The following is a description of a gene set: Binding to a phospholipid, a class of lipids containing phosphoric acid as a mono- or diester. Mouse Gene Set: GOMF_PHOSPHOLIPID_BINDING species: Mus musculus, and this is the list of marker genes: F10, Carmil2, Defb7, Defb5, Amer3, Nr5a1, Atp8b1, Rasgrp1, Cd300lf, Trim72, Myo1e, Map1lc3a, Cidea, Plek2, Cpne8, Arap2, Syt5, Rapgef6, Hgs, Vil1, Syt11, Slc9a3, Snx31, Jchain, Gramd2a, Pla2g2c, Ighm (immunoglobulin heavy constant mu), Gramd1b, Psd2, Atp13a2, Apoh, Irgm1, Pxk, Sytl5, Pla2g4a, Arap3, Epb41, Syt12, Pla2g2d, Rs1, Myof, Snx20, Atg2a, Ncf1, Rubcnl, Prex1, Snx30, Washc2, Zfyve9, Axl, Arhgap9, Osbpl5, Ing2, Pirt, Phlda2, Cibar1, Snx18, Wdfy1, Defb6 (defensin beta 6), Itpr1, Golph3, Ophn1, Mapkap1, Anxa1, Numa1, Pla2g4d (phospholipase A2, group IVD), Itpr3, Gabarapl1, Pctp, Vdac2, Adgrb1, Itpr2, Baiap3, Pacsin2, Snx17, Snx3, Opa1, Snx33, Osbpl2, Syt9, Arl6, Timd2, Pitpnc1 (NCBI Gene Id 77221), Cideb (NCBI Gene Id 68665), Mcf2l, Amer1, Snx14, Mme, Twf1, Aida, Fcgr4, Unc13c, Cps1, Pla2g2f, Bscl2, Vps13b, Defb3, Syt17, Jph2, Apoa1 (apolipoprotein A-I), Igtp, Cadps, Plekha4, Pitpna, Gga3, Ckmt2, Tpcn2, Irgm2, Racgap1, Golph3l, Gap43, Atg2b, Havcr1, Mark1, Vill, Plekha1, Ptafr, Rbsn, Anxa3, Dab2ip, Wdfy3, Snx15, Gsdmc3, Syt4, Dennd1b, Abca1, Eea1, Timd4, Kcnh1, Mtss1, Epn2, Appl2, Zcchc14, Plekha5, Sytl4, Flii, Avil, Gsdma3, Pcyt1b, Nf1, Fuz, Hip1r, Pacsin1, Rasa4 (NCBI Gene Id 54153), Cyth3, Zfyve28, Hspa8, Apoe, Defb4 (NCBI Gene Id 66348), Gab2, Dnm1, Apoc3, Sytl3, Dpep1, Apob, Ceacam2, Baiap2l2, Tpcn1, Plekhb2, Anxa9, Arhgap32, Acap2, Plcb2, Snx5, Fabp1, Ucp1, Vnn1, Dgka (diacylglycerol kinase, alpha), Lpar1, Cln6, Mtss2, Mitd1, Sh3pxd2a, Plekha2 (NCBI Gene Id 97502), Nsfl1c, Picalm, Clvs1, Kcnj1 (potassium inwardly-rectifying channel, subfamily J, member 1), Fcho2, Arhgap26, Pemt, Amph, Arhgap35, Pla2g4c, Ap2a2, Tirap, Syt7 (NCBI Gene Id 78663), Mctp2, Lpar3, Apoa4, Dnm2, Fermt2, Rcsd1, Ppt1, Plcb1, Dysf, Uqcc3, Got2, C2cd2l, Pick1, Hcn1, Obscn (NCBI Gene Id 380698), Gsdme, Exoc7, Nup62cl, Jag1, Iqgap2, Enthd1, Chmp3, Pik3c2g, Kif16b, Agap1, Gsdma2, Snx32, Pla2g4f, Ogt, Syt3, Plcd1, Mbl1, Osbpl8, P2rx2, Anxa6, Pla2g4b, Prkci, Anxa4, Pfn2, Bbs5, Bin1, Pla2g1b, Cpne9, Pla2g2a, Mreg, Inppl1, Tiam1, Epdr1, Mbl2, Bad, Gle1, Clint1, Iqgap1, Pard3b, Snx29, Snx24, Cpne4, Mfge8, Anxa13, Gsdmc2, Arap1, Tom1l1, Snx25, Unc13b, Scarb1 (scavenger receptor class B, member 1), Syt13, Anxa2, Gpr119, Cptp, Cgas, Tulp3, Esyt2, Snx27, Cpne3, Syt8, Sdcbp, Tln1, Snx7, Smpd3, Pclo, Defb8, Zfyve26, Dennd1a, Noxo1, Exoc8, Sestd1, Adap2, Sh3pxd2b, Gsdmc, Fundc2b, Gltp, Gsdmd, Capg, Cidec (NCBI Gene Id 14311), Trem2, Nup62, Deptor, Grb7, Kcnj2, Actn2, Rnf34, Syt1, Rps6kc1, Akt1, Sdcbp2, Psap, Commd1, Nlrp3, Snx10, Snx21 (NCBI Gene Id 70479), Pacsin3 (protein kinase C and casein kinase substrate in neurons 3), Gga1, Arfip1, Slc9a1, Micall1, Unc13a, Syt16, Pla2g4e, Scin, Sgip1, Trpv1, Serpina5, Wdpcp, Gsdmc4, Bin2, Chmp2a, Gga2, Intu, Epn3, Arhgap33, Dab2, Zfyve1, Tpp1, Fzd7, Stam, Pigu, Doc2a, Npm1, Nup35, Rag2, Sap30l, Pfn1, Lancl2, Snap91, Plcz1, Rubcn, Exoc1, Timd5, Wdr45b, Anxa10, Wipi1, Dab1, Laptm4b, Arfip2, Stoml2, Snx4, Pxdc1, Dok7, Nisch, Veph1, Ncf4, Snx6, Adap1, Asap1, Plekhf2, Dppa1, Anxa5 (annexin A5), Gpr12, Zfyve19, Lpar4, Gas6, Gpaa1, Syt14, Gsn, Pla2g2e, Phlda3, Aldob, Twf2, Sptbn1, Apba1, Apom, Esyt3, Svil, Kcnj3, C2cd5, Phlda1, Zfyve16, Snx1, Apoa5, Bltp2 (bridge-like lipid transfer protein family member 2), Bcas3 (BCAS3 microtubule associated cell migration factor), Plekhf1, Plekhn1, Btk, Plekha3, Gabarap, Pik3c2a, Pard3, Rufy4, Hmgb1, Sytl2, Tulp1, Mppe1, Myo1c, Pitpnm2, Phf12, Syt2, Frmpd2, Snx22, Cpne7, Spata18, Otc, Snx13, Stam2, Septin5 (NCBI Gene Id 29860), Gbf1, Faah, Krit1, Marcks, Sbf2, F3, Pla2g7, Pltp, Ttpal (tocopherol (alpha) transfer protein-like), Fes, Vps36, Doc2b, Frmpd4, Snx11, Snx12, Ttpa, Esyt1, Cd300a, Tom1, Myo10, Anxa8, Pld2, Nme4, Scarb2, Rasa2, Dapp1, Pask, Pnpla3, Vamp2, Kcnq1, Oc90, Timd6, Bdh1, Clvs2, Gsdma, Wipi2, Amer2, Cert1, Tnfaip8l3, Psd, Cpne1, Myo1g, Pcyt1a, Anxa7, Rph3a, Rapgef2, Vdac1 (NCBI Gene Id 22333), Fundc2, Cpne6, Snx9, Wdr45, Nr5a2, Pla2g5, Mtm1, Snca, Map1lc3b, Snx8, Syt6, Fgd2, Apoa2, Epn1, Cpne5, Osbpl10, Syt10, Ticam2, Rlbp1, Ldlrap1, Nrgn, Rpe65, Snx16, Myo1b, Anxa11, Dennd1c, Zcchc2, Pitpnb, Plekha8, Thy1, Arhgap44, Thbs1, Hip1, Osbp, Fchsd2, Tecpr1 (NCBI Gene Id 70381), Ccdc88a, Alox15, Appl1, Hs1bp3 (NCBI Gene Id 58240), Cfl1, Ankfy1, Snx2, Pld1, Syt15, Cpne2, Snx19, Pon1, Ceacam1, Sh3yl1, Sgk3, Pla2g10, Cavin2, Gltpd2, Rab35, Pitpnm1, Gabarapl2, Map1b, Tom1l2